Given this list of marker genes RPGRIP1, ZDHHC21, ACTR6, MPHOSPH9, RBM45, KMO (NCBI Gene Id 8564), DRAM1, PROSER1, GSTM5, ZC3HAV1L, ZMAT2, SFXN2, SCIN, ELP1, FGL2, DEPDC1, DONSON, CST7, KGD4, C9orf85, NCAPD3, ZBTB11, SNORD89, KIF1B, BLOC1S4, ZNF706, OSBPL2, S1PR2, ACOT9, UTP23 (UTP23 small subunit processome component), DOLK, CLEC4E, RSBN1, FFAR2, CSTF3, SLC43A3 (NCBI Gene Id 55543), FASTKD3, PITPNB, AKNA, SZT2, AVPR1B (NCBI Gene Id 553), ATP5F1A, POPDC3, DCK, BLM, ZBTB34, ADNP2, EIPR1, MED6, TIGAR, FAM111A, GPSM1, AGPAT5, POLR1D, TBC1D15, CCDC34, NKRF, IRF2BP2, VAMP4, TASP1, VAPA, CNMD (NCBI Gene Id 373170), TXNDC9, PKD2L2, TAOK1, CDC25A, MYO5A, C6orf62, RAD54B, CKAP4, ZDHHC5, GALNT15, GRN, LACTB, MTMR4, PARL, GRAMD2B, PXYLP1, RP2, PLCB1, ZNF654, NUP62, MTMR6, LTA4H, ATG4A, SH3KBP1, CCNC, CLEC10A, TACC2, KCNK6, BLOC1S2, CDH1, GANC, CEP128, SRGN, ATP1B1, FLVCR1, ELANE, SCP2, ZNF330, MASTL, BCO1, RAD54L, CHFR, DDI2, KDM1B, GNG10, GET3, BLTP3A (NCBI Gene Id 54887), TRNT1, FUCA2, CIP2A, SYCE2, TREML4, OAZ1, ARHGAP19, GMIP, SCFD2, EML5, MIS18BP1 (NCBI Gene Id 55320), HADHB, TOP3B, RPGR, MRPS9, BTNL9, ANXA2, KRR1 (KRR1 small subunit processome component homolog), MCC, TCAIM, ALAS1, ACLY, ANAPC10, ANGPTL4, RIF1, SEC22C, RTTN (rotatin), ENDOD1, RRS1, TSHZ1, AKIRIN1, NDUFA5, SLC4A7, LRIF1, IRAK4, ZSCAN21, SRSF1, URB2, UMAD1, SMARCD2, DGAT2, RAB1A, DNAJC11, NDUFB6, TTC16, ESCO2, BRCA1, SIVA1 (SIVA1 apoptosis inducing factor), CA9, NDUFAF4, IBTK, OTULINL, PTGER2, TSPAN2, EMB, SDF2L1, PLEKHF1, ERCC6L, STT3B, SLC16A10, DAP, POLR3A, FASTKD1, TM6SF1, RNPC3, SACS, MTMR2, ZBTB44, OFD1, ERN1, CIT, HDHD2, MXD3, CEMIP2, SH3BGRL, TIRAP, ZNF367, LATS2, SYNJ2 (NCBI Gene Id 8871), LONRF1, DHDH, HSPA4, GAL3ST1, KBTBD8, CASK (calcium/calmodulin dependent serine protein kinase), ZNF143, SRPK1, CASP8AP2, SORL1, MRPL33, MYO7A, here is a description of the gene set: Among the multiple mechanisms that control the intensity and duration of macrophage activation, the development of a state of refractoriness to a second stimulation in cells treated with LPS has long been recognized. Release of inhibitory cytokines and alterations in intracellular signaling pathways may be involved in the development of LPS tolerance. Although a number of molecules have been implicated, a detailed picture of the molecular changes in LPS tolerance is still missing. We have used a genome-wide gene expression analysis approach to (i) define which fraction of LPS target genes are subject to tolerance induction and (ii) identify genes that are expressed at high levels in tolerant macrophages. Our data show that in LPS tolerant macrophages the vast majority of LPS-induced gene expression is abrogated. The extent of tolerance induction varies for individual genes, and a small subset appears to be excepted. Compared to other negative control mechanisms of macrophages, e.g. IL-10-induced deactivation, LPS-tolerance inhibits a much wider range of transcriptional targets. Some previously described negative regulators of TLR-signaling (e.g. IRAK-M) were confirmed as expressed at higher levels in LPS-tolerant macrophages. In addition, we discuss other potential players in LPS tolerance identified in this group of genes. Human Gene Set: GSE8621_LPS_PRIMED_UNSTIM_VS_LPS_PRIMED_AND_LPS_STIM_MACROPHAGE_DN from publication Mages J, Dietrich H, Lang R (PMID 18086374) Genes down-regulated in tolerant microphages: untreated versus LPS. species: Homo sapiens